The following is a description of a gene set: studied in species Homo sapiens The internalization mechanism of leishmania parasites depends on not only the dynamic nature of the parasite's surface, but whether it is a non infective (procyclic) or infective (metacyclic) promastigote or infective amastigote, and also its virulent nature (Ueno et al. 2012 & Lee et al. 2018). Host receptors reported to facilitate Leishmania internalization include the third complement receptor (CR3), first complement receptor (CR1), mannose receptor (MR), Fc gamma receptors (FCGRs) and fibronectin receptors (FNRs). The route of entry to the macrophage can affect the fate of the Leishmania parasite. Reactome Pathway: Leishmania phagocytosis part of: Parasite infection, and this is the list of marker genes: IGHV3-33 (immunoglobulin heavy variable 3-33), IGHV1-46, MAPK1 (NCBI Gene Id 5594), MYO9B, IGLV6-57, IGLV7-43, IGKV1-39, SYK, IGKV1D-39, VAV2 (vav guanine nucleotide exchange factor 2), IGHV2-70, IGLC1, MYO10 (myosin X), CYFIP1, CRK, ARPC5, WIPF2, WIPF3, IGKV1-33, NCKIPSD, IGHV, IGHG3, ACTG1, ELMO1, IGLV2-8, IGHV3-9, NCK1, IGLV3-22, IGLV4-69, IGLC6, IGLV2-33, IGLC2, ABI2, IGHV3-11, IGKV2D-28, ELMO2, BRK1, MAPK3, IGLV1-47 (immunoglobulin lambda variable 1-47), BAIAP2 (BAR/IMD domain containing adaptor protein 2), IGLV8-61, IGKV1-5, ARPC1B, IGLV3-27, IGKV3D-20, RAC1, IGLV1-51, IGKV1-12, FYN, IGHV4-39, IGKV2-29, IGHV2-5, IGHV3-23 (NCBI Gene Id 28442), ACTR2, IGKV2-28, IGLC3, IGHG4, IGLC7, YES1, IGKV1D-16, IGLV4-60, SRC, WASL, NCKAP1, CD3G, IGHG1, IGLV1-40, WASF1, PTK2, IGKV1D-33 (NCBI Gene Id 652694), VAV3, IGKV2-30, IGHV3-53, LPG1G2, IGKV1-17, IGLV2-11, ACTR3, HCK, IGKV3-11, IGLV3-12, IGLV3-16, IGLV3-21, IGLV4-3, MYO1C, NCKAP1L, IGLV5-45, ARPC3, LYN, ABL1, ARPC1A, VAV1, IGKV3-20, IGLV3-19, GRB2, IGHV3-48, WASF2, IGKV1D-12, IGHV3-7, IGLV1-36, IGKC, MYO5A (NCBI Gene Id 4644), MYH2 (myosin heavy chain 2), IGLV, IGLV10-54, IGKV2D-30, FGR, IGKV2D-40, WIPF1, IGKV1-16, IGHG2, IGLV3-1, CDC42, IGHV1-2, IGLV11-55, IGLV7-46, ARPC4, FCGR3A, IGLV2-23, MYH9, ARPC2, ACTB, IGHV3-13, IGHV7-81, IGHV4-34, IGLV3-25, WAS, CD247, IGHV4-59 (NCBI Gene Id 652128), IGLV2-14, IGLV2-18, IGLV1-44, IGHV3-30, DOCK1, WASF3, IGHV1-69, IGKV4-1 (NCBI Gene Id 28908), IGKV5-2, IGLV5-37, CYFIP2, IGKV3-15, BTK, ABI1